Given this list of marker genes MZT2B, EIF3I, GNA12, NDUFB8, PHB2, KIAA0040, HNRNPF, CCT7, ERP29, IGBP1, CBX7, TBCA, MRPS34, ZNF32, NENF, NDUFS7, DECR2, CLPTM1, POLR2F, EPS8L2, PSMB6 (NCBI Gene Id 95505), DFFB, TRADD, ECSIT, PSMD8, SLC22A6, ANXA6, SPECC1L, ATP5MC2, MPDU1, TCF20, RAN, CFB, CD2BP2, MRPL23, SUN2, NDUFB11, STOML2, SET, MCM5, FUS, PIM1, SNRNP35, THADA (THADA armadillo repeat containing), DAP3, ECI1, SRPK2, PDCD5, DYNLRB1, RBP3, COPS6, DMAC2, NDUFS6, PSMD13, EEF2, HIVEP2, ATP5PD, PBX2, NTHL1, GTPBP6, PIN4, CYB561D2, ENSA, CDC42SE1, MRPL58, NUMA1, MTHFD1, MPI, UQCR11, STARD7, LSM7, SLC35D2, ATP5MF, ATP5MC1, ATP5IF1, RALGDS, PLEKHJ1, GANAB, RIPOR2, HDHD5, ISG20, YARS2, LAMTOR2, POLR2I, ZNF428, ANXA11, FLNA (NCBI Gene Id 8272), PIN1, PARL, COX6B1 (cytochrome c oxidase subunit 6B1), RFXANK, R3HCC1, GRHPR, IRF4, HMGN2, MRPS16, AAMP, RANGRF, FASTK, UQCRQ, APH1A, EDF1, CLASRP, NDUFB4, SNRNP25, ATP5PO, ARF5 (ADP ribosylation factor 5), EIF3F, ARL6IP4, ARL6IP5, CAPZB, SDHC, ETHE1, UQCRH, AEN, HSD17B10, UBL5, PFKP, UQCR10, NME1, UGCG, EBNA1BP2, SOD1, TRMT5, NPM3, ARPC1B, DRAP1, TRAPPC2L, SHMT2, NFATC1, ADSL, NDRG3, NIPSNAP1, HDHD3, COX5A, NDUFA2, SEPTIN9, RPL6, BANP, BCS1L, INTS15 (NCBI Gene Id 79034), MZT2A, DBI, SLC25A6, BCCIP, RAB5C, LMAN2, TOR3A, TFPT, XRCC6, CASP4, DPM3, DALRD3, GMFG, UBE2Z, PSMD4, KRT10, AUP1, TWF2, AHCY, VOPP1, SLC35C1, HEMK1, UBE2K, MRPL40 (NCBI Gene Id 8699), SAE1, DNPH1, RPS9, PRPF31, PSMD9, ETFB, UCKL1, NDUFA7, ATP5F1E, NUDT1, DDT, PDIA3, CTDNEP1, COPZ1, OCEL1, PRMT1, AP2B1, SNRPF, MPG, RASGRP2, PSMC5, HSPB1, PITPNM1, COG4, SNRPD2, RBCK1, DDX49, COX8A, MRPS11, LCMT1 (NCBI Gene Id 51628), BST2, RPS7, EIF3K, KCNN4, TOE1, here is a description of the gene set: Genes down-regulated in plasmacytoid dendritic cells: wildtype versus GFI1 knockout. from publication Chow KT, Schulz D, McWhirter SM, Schlissel MS (PMID 24086657) Human Gene Set: GSE45837_WT_VS_GFI1_KO_PDC_DN studied in species Homo sapiens Growth factor independence genes (Gfi1 and Gfi1b) repress recombination activating genes (Rag) transcription in developing B lymphocytes. Because all blood lineages originate from hematopoietic stem cells (HSCs) and different lineage progenitors have been shown to share transcription factor networks prior to cell fate commitment, we hypothesized that GFI family proteins may also play a role in repressing Rag transcription or a global lymphoid transcriptional program in other blood lineages. We tested the level of Rag transcription in various blood cells when Gfi1 and Gfi1b were deleted, and observed an upregulation of Rag expression in plasmacytoid dendritic cells (pDCs). Using microarray analysis, we observed that Gfi1 and Gfi1b regulate a broad spectrum of cellular processes in pDCs, but not a lymphoid specific transcriptional program. This study establishes a role for Gfi1 and Gfi1b in Rag regulation in a non-B lineage cell type